The following is a description of a gene set: Any process that activates or increases the frequency, rate or extent of the formation and development of a tooth or teeth. Human Gene Set: GOBP_POSITIVE_REGULATION_OF_ODONTOGENESIS species: Homo sapiens, and this is the list of marker genes: EDN1, CD34, NGFR, BMP2, TGFB1, MSX1, CSF1